Given this list of marker genes LZTFL1, MASP2, HPS1, PRF1, FASLG, EDN3, MKS1, STXBP2, CTLA4, INAVA, ECE1, WIPF1, CHD8, CEP19, FERMT1, FXN, RTEL1, STX11, IRGM (immunity related GTPase M), CYBC1, BBS4, SMO, TCF4, TNFAIP3, NCF4, SCAPER, SLC9A3, ERBB3, ARPC1B, CARD11, BBS5, ABCB1, SKIC3, WDPCP, GPIHBP1, EDNRB, MST1, COG6, PTPN6, RBCK1, SDCCAG8, PSTPIP1, BBS10, NCF2 (NCBI Gene Id 4688), SREBF1, ZAP70, SLC37A4, SEMA4D, SKIC2, CASP10, BBS9, LYN, SHARPIN, NOP10, FAS, POLA1, FOXP3, SEMA3C, MYH11, IFT172, FH, F13B, DOCK11, ARL6, TGFB1, JAK1 (Janus kinase 1), ACADVL, DCLRE1B (DNA cross-link repair 1B), ATP7A (ATPase copper transporting alpha), IL6, DOCK2, RIPK1, PSMB10, IL10RA, PLCG2, WAS, XIAP (NCBI Gene Id 8257, X-linked inhibitor of apoptosis), CARD8 (NCBI Gene Id 22900), MEFV, CIITA, DKC1, IVNS1ABP, IL37, HLA-B, PIGY, TTC8, CARMIL2, PI4KA, NPHP1, IKBKG, RET, OPLAH, SCLT1 (sodium channel and clathrin linker 1), NOD2, BBIP1, NFKBIA, GDNF, LRBA, BBS7, IL10RB, ERBB2, SEMA3D, UNC13D, ELF4, BCL10 (BCL10 immune signaling adaptor), STAT1, CEP290, IFT74, IL21, HLA-DRB1, MAP3K7, BACH2, TTC7A, TRIM32, DEF6, IFT27, ABCD1, PIK3CD, F13A1, MKKS, ELANE, BBS2, NRTN, BBS1, PIK3CG, GPR35, BBS12, SYK, FCHO1, FCN3, CFAP418, NLRC4, here is a description of the gene set: Human Gene Set: HP_INFLAMMATION_OF_THE_LARGE_INTESTINE Inflammation, or an inflammatory state in the large intestine. Inflammation of the large intestine studied in species Homo sapiens